Given this list of marker genes Chrna3, Chrnb2, Chrnd, Chrng, Chrne, Chrnb4, Chrna4, here is a description of the gene set: species: Mus musculus Highly sodium permeable postsynaptic acetylcholine nicotinic receptors Mouse Gene Set: REACTOME_HIGHLY_SODIUM_PERMEABLE_POSTSYNAPTIC_ACETYLCHOLINE_NICOTINIC_RECEPTORS